Given this list of marker genes ZNF384, TLX3, STK11, EPS15, DDB2, RUNX1 (NCBI Gene Id 861), TCL1A, TOP1, TPR, JAK2, EWSR1, OLIG2, MYCL, FLT4, TTL, NFKB2, FANCG, RET (NCBI Gene Id 5979), TAL2, FUS, ARHGAP26, MSH6, KDSR, WRN, MLH1, GOPC, PIK3CA, LHFPL6, ARNT (NCBI Gene Id 405), FLI1, MALT1, NOTCH1, ATM, RNF213, CBFA2T3, DDX10, BIRC3, FANCE, HIP1, ERC1, GOLGA5, USP6, PRKAR1A, PLAG1, COX6C, TFEB, PRDM16, SMARCB1, CLP1, CHIC2, PAX5, FANCA, TCF3, CYLD, NACA, LIFR, MYC (NCBI Gene Id 731404), HSP90AA1, FANCD2, HOXA9, SYK, ABL1, ASPSCR1, CCDC6, EP300, XPC (XPC complex subunit, DNA damage recognition and repair factor), IKZF1, CNTRL, POU2AF1, CBL, DDX6, SUFU, MECOM, CDKN2A, SS18L1 (NCBI Gene Id 26039), SMAD4, TNFRSF17, NPM1, FANCF (NCBI Gene Id 2188), TRIM33, LPP, TFG, TEC, FAS, MAP2K4, KTN1, KIT, ERBB2, NUMA1, PTEN, SMO, TCF12, FLT3, CDX2, TRIP11, TPM3, BCL11B, ZMYM2, FCRL4, STIL, MUC1, NUP214, OMD, PCM1, KLF6, ETV6, NSD3 (NCBI Gene Id 54904), TRIM24, MAML2 (mastermind like transcriptional coactivator 2), SEPTIN9, LASP1, PDGFRA, EIF4A2, TPM4, GMPS, PMS2, TMPRSS2, REL, FCGR2B, ERCC4, PAFAH1B2, EXT2, TAF15, CBFB, TCEA1, SET (SET nuclear proto-oncogene), PPARG, SRSF3, AFF3, RUNX1T1, CNBP, FGFR1, HMGA1, NRAS, CDK4, BCL11A, SDHC, FOXO3, CLTC, MLLT3, HOXA13, HOXA11, CEP43, NR4A3, IL2 (NCBI Gene Id 3558), NF1, CDK6, NSD1, NTRK3, RABEP1, MLF1, CEBPA, BCR, FH, NBN, MLLT6, TSHR, SPECC1, HOXD11, MSI2, ITK, TLX1, PMS1, BTG1, GAS7, ABI1, MET, DEK (NCBI Gene Id 7913), TP53, ERG, MAFB, MEN1, NCOA4, ARHGEF12, XPA, ELL, BUB1B, PML, MLLT10, SDHD, MUTYH, RAD51B, ABL2, ACKR3, APC, MYCN, PIM1, TFRC, CALCR (calcitonin receptor), ERCC3, NUP98, AFF1, H4C9, SBDS, HMGA2 (NCBI Gene Id 8091), ATIC, FGFR2, CCND2, AFDN (NCBI Gene Id 92217), ATF1, NSD2, FSTL3, SEPTIN5, KNL1, MYH9, PAX7, BCL3, AKT2, BLM, RB1, HRAS, HOXD13, FEV, CARS1, NIN, PDGFB, SDHB, MN1, FBXW7, TAL1, RPN1, CLTCL1, LMO1, CCNB1IP1, PATZ1, ROS1, BCL6, CHEK2, SS18, MYH11, CHN1, RAP1GDS1, GNAS, BCL9, LCK, PAX8, BRCA2, JAZF1, CIITA, PRRX1, RARA, NF2, ZBTB16, ETV4, TET1, PCSK7, RBM15, IL21R, PTPN11, MNX1, MLLT11, FNBP1, FOXO1, PER1, NCKIPSD, FGFR3, RPL22, WT1, GPHN (gephyrin), LYL1 (LYL1 basic helix-loop-helix family member), HNF1A, CTNNB1, CDH11, SUZ12, FLCN, ETV1, BRCA1, PAX3, PDGFRB, PHOX2B, SFPQ, AFF4, ACSL6, KRAS, FIP1L1, RECQL4, CCND1, PRCC, RANBP17, NTRK1, LCP1, NCOA2, BCL10, COL1A1, SH3GL1, PBX1, KMT2A, MAF, HSP90AB1, MDS2, TFPT (NCBI Gene Id 29844), VHL, FANCC (NCBI Gene Id 2176), PDE4DIP, MSH2, LMO2, KAT6B, PSIP1, HOXC13, IRF4, BCL2, TSC1, DDIT3, HLF, BRAF (B-Raf proto-oncogene, serine/threonine kinase), ERCC2, EGFR, CDH1, MLLT1 (MLLT1 super elongation complex subunit), ZNF331, TSC2, PICALM, CREBBP, RHOH, EXT1 (NCBI Gene Id 3966), THRAP3, CCND3, ALK, HOXC11, BMPR1A, ERCC5 (ERCC excision repair 5, endonuclease), BRD4, here is a description of the gene set: Genes from common genomic gains observed in a meta analyis of copy number alterations across a panel of different cancer cell lines and tumor samples. from publication Greshock J, Nathanson K, Martin AM, Zhang L, Coukos G, Weber BL, Zaks TZ (PMID 17440070) Tumor-derived cell lines are used as in vitro cancer models, but their ability to accurately reflect the phenotype and genotype of the parental histology remains questionable, given the prevalence of documented cell line-specific cytogenetic changes. We have addressed the issue of whether copy number alterations seen in tumor-derived cell lines reflect those observed in studies of fresh tissue by carrying out a meta-analysis of array-based comparative genomic hybridization data that considers both copy number alteration frequencies and the occurrence of cancer gene amplifications and homozygous deletions. Pairwise correlation comparisons between the data sets of seven diagnosis-specific matched tumor and cell line groups indicate that the trends in aberration frequencies are highly correlated between tumors and cell line sets of matched cancer histology relative to unmatched pairings. Despite their similarities, cell lines showed uniformly higher locus-specific alteration frequencies (P = 0.004) and several recurring cell line-specific alterations emerged. These include the previously documented losses of 13q and 9p and gains of 20q, as well as additional undescribed cell line-specific gains of 5p, 7p, and 17q and losses of 18q and 4q. These results indicate that, on average, cell lines preserve in vitro the genetic aberrations that are unique to the parent histology from which they were derived while acquiring additional locus-specific alterations. These data may enable a more predictive understanding of individual cell lines as in vitro models of cancer biology and therapy. species: Homo sapiens Human Gene Set: GRESHOCK_CANCER_COPY_NUMBER_UP